The following is a description of a gene set: The establishment of an organism's body plan or part of an organism such that a similar arrangement in form and relationship of parts around a common axis, or around each side of a plane is created. Human Gene Set: GOBP_SPECIFICATION_OF_SYMMETRY studied in species Homo sapiens, and this is the list of marker genes: DAAM2, HAND1, NME7, GATA4, GREM1, RIPPLY2, TBX3, DISP1, CRIPTO, CCDC103, DNAAF3, DNAH5, DDIT3, LBX1, GREM2, TBC1D32, TGFBR2, SHH, CFAP53, TGIF1, DNAI2, DAW1, WNT3A, NPHP3, BICC1, MMP21, TBX20, CFAP52, NKX2-5, DNAAF4, MKKS, SOSTDC1, SOX17 (NCBI Gene Id 64321), BBS7, DNAAF11, PSEN1, ODAD4, PIERCE2, ACVR2A, PIERCE1, DNAAF1, MESP1, ACVR2B, FOXJ1, DNAH11, DPCD, RPGRIP1L, IFT172, CIROP, SMAD3, ZIC3, CTNNB1, AIDA, FOXF1 (NCBI Gene Id 2294), VANGL2, DYNC2H1, DYNC2LI1, OVOL2, NOTCH2, DNAAF2, NCLN, SOX18, RFX3, C1orf127, NBL1, SMO, DAND5, DNAI1, ACVR1, IHH, FOLR1, IFT74, DVL1, IFT52, FOXN4, SMAD2, DLL1, PITX2, CER1, MICAL2, CC2D2A, ODAD3, SETDB2, DVL2, STIL, BBS5 (NCBI Gene Id 428), NEK8, ENG (endoglin), CRIPTO3, ENKUR, LEFTY1, TMED2, MIB1, NOTCH1, PCSK6, KIF3B, ALDH1A2, SUFU, IFT140, GALNT11, CITED2, NOMO1, RNF207, AP1B1, CFC1B, NDRG4, WNT5A, CFC1, TMEM107, TBX1, ALG5, PKD2, NOTO, ASB2, CCDC40, MICOS10-NBL1, ARL6, NODAL, FOXH1, CLUAP1, ODAD2, ANKS6, PKD1L1, PSKH1, C2CD3, TBX2, IFT57, APLNR, NKX3-2, WNT8B, AHI1, GAS8, ARL13B, MKS1, DRC1, SRF, NOMO3, RTTN, HAND2, FGF8, CCDC39 (coiled-coil domain 39 molecular ruler complex subunit), FGF10, CFAP45, OFD1, MEGF8, HIF1A, MEF2C